The following is a description of a gene set: from publication Marzec M, Halasa K, Kasprzycka M, Wysocka M, Liu X, Tobias JW, Baldwin D, Zhang Q, Odum N, Rook AH, Wasik MA (PMID 18281483) studied in species Homo sapiens In this study, we compared the effects of interleukin-2 (IL-2), IL-15, and IL-21 on gene expression, activation of cell signaling pathways, and functional properties of cells derived from CD4+ cutaneous T-cell lymphoma (CTCL). Whereas both IL-2 and IL-15 modulated, in a CTCL cell line, the expression of >1,000 gene transcripts by at least 2-fold, IL-21 up-regulated <genes. All three cytokines induced tyrosine phosphorylation of Jak1 and Jak3 in CTCL cell lines and native leukemic (Sezary) cells. However, only IL-2 and IL-15 strongly activated signal transducers and activators of transcription 5, phosphoinositide 3-kinase/Akt, and mitogen-activated protein/extracellular signal-regulated kinase (ERK) kinase/ERK signaling pathways in the cell lines and mitogen-primed native cells. In contrast, IL-21 selectively activated signal transducers and activators of transcription 3. Whereas all three cytokines protected CTCL cells from apoptosis, only IL-2 and IL-15 promoted their proliferation. The effects of the cytokine stimulation were Jak3 kinase- and Jak1 kinase- dependent. These findings document the vastly different effect of IL-2 and IL-15 versus IL-21 on CTCL cells. They also suggest two novel therapeutic approaches to CTCL and, possibly, other CD4+ T-cell lymphomas: inhibition of the Jak1/Jak3 kinase complex and, given the known strong immunostimulatory properties of IL-21 on CD8+ T, natural killer, and B cells, application of this cytokine to boost an immune response against malignant CD4+ T cells. Human Gene Set: MARZEC_IL2_SIGNALING_UP Genes up-regulated by IL2 in cells derived from CD4+ cutaneous T-cell lymphoma (CTCL)., and this is the list of marker genes: HK2, GNL3, IL13, POLR1B, VEGFA, MAPKAPK2, IER3, CCL3, DKC1, RHOB, BCL2, CCND3, SOCS1, TNFSF10 (NCBI Gene Id 8743), ADCY3, STAT3, PTCH1, OSM, ACVR1B, NOP2, TRIB3, TNFAIP8, CXCL12, GART, IL5, HSPD1 (NCBI Gene Id 56733), CCR4, ADCY9, LIF, BCCIP, AHR, CISH, TNFRSF10A, PPAT, DUSP2, PUS1, POLR1C, IL17RB, MAP3K20, DLST, PEA15, POLR3K, PDCD11, TNFRSF21, SPP1, SERPINB9, TNFRSF1B, SOCS2, POLE2, JUND, CSF2RB, CTPS1, PHLDA1, DUSP7, IL2RA, DUSP4, BMP2, PINX1, CSF2RA, TGFB1, CDC25A, CARD10, PNP, FGFR1, TNFRSF8, PIM1, PHLDA2, IL10, WT1, FGF2, ELMO3, MYC, SPRED1, CSRNP1, PTPN7, PDCD2L, TNFRSF18 (TNF receptor superfamily member 18), GADD45B (NCBI Gene Id 4616), FGF7, CARD9, PDE4A, UCK2, TNFRSF4, UMPS, IL2RB, CDK5R1, DUSP6 (dual specificity phosphatase 6), RGCC, CCND1, CCNE1, CSF2, TNFSF14, CXCL8, CDC6, PRKX, PTRH2, SPRED2, TNFRSF9, CCND2, BIRC3, IL10RA (NCBI Gene Id 3587), BCL2L1, CCNE2, IL18RAP, DHODH, BAG1, POLR2D, IL1A, CD40LG, AK4P3, EEF1E1, HSPA1B, TNFRSF12A, RRAS2, IL24